The following is a description of a gene set: studied in species Homo sapiens Reactome Pathway: Organelle biogenesis and maintenance This module describes the biogenesis of organelles. Organelles are subcellular structures of distinctive morphology and function. The organelles of human cells include: mitochondria, endoplasmic reticulum, Golgi apparatus, vacuoles, nucleus, (auto)phagosome, centriole, lysosome, melanosome, myofibril, nucleolus, peroxisome, cilia (in some cell types), proteasome, ribsome, and transport vesicles., and this is the list of marker genes: SMARCD3, TGS1, ATP5MK, CDK1 (NCBI Gene Id 983), IFT140, PRKAB2, PRKAA2, BBIP1, DYNC2H1, IFT57, APOO, IFT43, CNGB1, HAUS7, EXOC8, NINL, PRKAG3 (protein kinase AMP-activated non-catalytic subunit gamma 3), APOOL, SOD2, CEP89, RXRA, TUBG1, TCTN1, MED1, EXOC5, MCHR1, CEP63, SIRT5, CETN2, CEP135, ATP5PB, DCTN2, CCT2, DYNLT2B, PPARGC1B, ATF2, HAUS4, IFT52, EXOC6, RAB3IP, DYNLL2, DYNC1I2, CEP192, CALM1, TUBB3, BBS1, IQCB1, BBS10 (NCBI Gene Id 79738), HAUS5, KIF3B, ATAT1 (alpha tubulin acetyltransferase 1), TUBA3E, CREB1, CEP250, LZTFL1, IFT122, SFI1, TCTN2, SMO, ATP5PF, ATP5F1E, CCP110, NCOR1, PKD1, PRKACA, CKAP5, MAPK11, PRKAG2, TTC21B, OFD1, TUBB6, KIF17, TUBA4A, HDAC3, BBS12, NRF1, BBS9, CEP70, HELZ2, TUBA3C, ATP5F1B, MTX2, DCTN1, CEP152, RAB8A, MAPRE1, ATP5PO, RAB11A, GLUD1, IFT70A, CEP162, RAB11FIP3, YWHAE, CEP43, IMMT, AHI1, TRAF3IP1, ATP5PD, CEP164, ARL13B, PPARA, CEP76, CRTC2, BBS2, CNGA4, SSNA1, SSTR3, SEPTIN2, HAUS3, MARK4, CSNK1D, C2CD3, ATP5MG, ASAP1, CARM1, DCTN3, CCT8, CCT5, ATP5F1C, RP2, ARL3, DYNC2I1, CHCHD6, MKS1, WDR35, ATP5F1D, BBS4, ARL6, PERM1, ATP5MC2, MICOS10, TFB1M, BBS5, NDE1, MEF2C, MAPK14 (NCBI Gene Id 1432), SSBP1, IFT70B, TNPO1, SDCCAG8, PRKAR2B, IFT20, B9D1, TUBB1, B9D2, ACTR1A, PCNT, TMEM216 (transmembrane protein 216), TUBA3D, MKKS, INPP5E, IFT27, CCT4, PKD2, HAUS8, RPGRIP1L, CYS1 (cystin 1), CREBBP, NPHP4, ATP5ME, HSPA9, TRIP11, CAMK4, HDAC6, TUBB2B, ARF4, PDE6D (phosphodiesterase 6D), CEP290, IFT46 (intraflagellar transport 46), TUBA1C, FBF1 (NCBI Gene Id 85302), CHD9, CEP83, AKAP9, CC2D2A (coiled-coil and C2 domain containing 2A), TMEM11, ALMS1, MTX1, PAFAH1B1, DNAJC11 (NCBI Gene Id 55735), CSNK1E, SIRT3, MT-ATP6, HAUS2, DYNC2LI1, TUBB4B, GABPA, KIFAP3, TUBA8, HSP90AA1, IFT74, CRTC3, NEK2, PLK1, EXOC2, HCFC1, EXOC1, KIF3C, SAMM50, ACSS2 (acyl-CoA synthetase short chain family member 2), MEF2D, CLASP1, IDH2, DYNLL1, TUBB2A, TBL1X, GABPB1, CNTRL, CPAP, EXOC3 (NCBI Gene Id 11336), MTERF1, TCTN3, CYCS, ATP5MF, ALAS1, IFT56, RHO, SIRT4, NR1D1, NCOA2, DYNC2I2, PPARGC1A, NCOA1, CEP78, DYNLT5, TCP1, NCOA6, TUBA1B, ATP5MC1, CEP57, CEP131, EXOC4, TFB2M, ATP5F1A, ODF2, CHCHD3, CEP72, POLG2 (NCBI Gene Id 11232), TTBK2, CCT3, ESRRA, IFT25, UNC119B, KIF24, DYNLRB2, HAUS1, MICOS13, NEDD1, TTC8, NPHP1, DYNC1H1 (dynein cytoplasmic 1 heavy chain 1), POLRMT, IFT22, TUBB8B, IFT81 (NCBI Gene Id 83713), CLUAP1, ATP5MC3, CEP97, NPHP3, CRTC1, TUBB, EXOC7, IFT172, DMAC2L, GLUD2, PPRC1, CNGA2, WDR19, GBF1, PPP2R1A, MT-ATP8, DYNLT2, TUBB8, PCM1, SCLT1, CEP41, MAPK12, KIF3A, BBS7, TUBAL3, YWHAG, HAUS6, TUBB4A, PLK4, CDK5RAP2, IFT80, TMEM67, PRKAG1, TWNK, DYNLRB1, IFT88, PRKAB1, TUBA1A, TFAM, TBL1XR1, ATP5MJ